The following is a description of a gene set: studied in species Homo sapiens An abnormality of the cardiac ventricular function. Human Gene Set: HP_ABNORMAL_CARDIAC_VENTRICULAR_FUNCTION Abnormal cardiac ventricular function, and this is the list of marker genes: SLC25A4, NPPA, RRAGD, ACTN2, SDHD, MT-TL1, MT-TF, MT-TS2, PPCS, VHL, GNPTAB, MT-TK, FBN1, LTBP1, NONO, LDLR, AARS2, ENPP1, FHL2, ABCG5, ABCC9, CSRP3, PLN, GTPBP3, MYH7, CORIN, TCAP, TGFBR2, ACADVL, SAA1, MYOZ2, PSEN2, B2M, TLL1, CAPNS1, NKX2-5, MYH6, TET2, VCL, LAMA4, MYZAP, LMNA, CITED2, BAG5, TPM1, GATA6, RAF1, COQ4, LDLRAP1, PPP1R13L, KCNJ2, POMT1, KLHL24, LDB3, BTNL2, MRPL39, DMD, MT-CO1, DYSF, DSP, FOXE3, ABCC6, POLG2, SLC6A6, SGCD, BMPR2, GET3, DVL1, LAMP2, KCNJ5, MYBPC3, HMGCR, CAP2, HLA-DRB1, TTR, APOB, TOP3A, DSG2, MT-TC, RPL3L, OTUD5, DOLK, TMPO, VEZF1, FBLN5, RRAGC, MT-ND1, TAFAZZIN, PRDM16, CRYAB (crystallin alpha B), MT-CO2, EFEMP2, SDHB, LAMA2, ADAMTS19, ABCG8, SDHAF1, LOX, RRM2B, TAB2, DES, SMAD2, WNT5A, KIF20A, GATA4, HEY2, JPH2, TWNK (twinkle mtDNA helicase), TTN, TNNI3, SELENON, GATAD1, NR2F2, TGFB3, FLII, MT-TW, MYLK, ANKRD1, MYH11, PSEN1, SGCG, MT-CO3, FKRP, MT-ND6, MYPN, MYL3, GAA, THSD4, SMAD4, NEXN, SDHA (NCBI Gene Id 6389), GJA5, CCND1, FLNC, BAG3, TAF1A, ATRX, TBX20, ELN, DLD, SLC34A2, SMAD3, RBM20, MT-CYB, GDF1, MT-TQ, POLG (NCBI Gene Id 5428), LMOD2, ROR2, TGFB2, PRKG1, TNNT2, TGFBR1, TXNRD2, MAT2A, TNNC1, MFAP5, MT-ND5, ACTA2, POMT2, FOCAD, SCN5A, HAND2, FKTN, COA6, EYA4, ALPK3, ATP13A3, ACTC1, FHOD3, MT-TV, ZMPSTE24, PCSK9, EIF2AK4